Given this list of marker genes Vipr2, Plp1, Rab8b, Ndufaf4, Fat3, Pter, Ncr1, Nfat5, Hoxd8, Wscd2, Adam10, Acot8, Ppp3r2, Unc5d, Spty2d1, Cask, Ctdspl2, Mtarc1, Sall2, Erbb4, Itprid2, Gria1, Igfbp2, Pnpt1, Serinc5, Slc38a9, Atp11c, Dpyd, Gm7609, Papolg, Gata6, Nphs2, Mef2c, Bicd1, Zfp503, Vegfa, Dennd5a, Dtna, 4930562C15Rik, Magi1, Mbnl3, Pik3ca, Cklf, Tead1, Epha7, Ank, Wdr7, Zfp710, Unc80, Zfp472, Drp2, Cyp3a44, Ddx6, Ppip5k2, Cldn19, Tbc1d8b, Pak2, Pnpla8, Zfp345, Zfp967, Cnot1, Tspan2, Tnik, Rngtt, Foxn2, Nptx1, Nexmif, Rbfox2, Cadm2, Kcnj6, Zbtb10, Sh3d19, Ankrd44 (NCBI Gene Id 545320), Nrf1, Zfp966, Pappa2, Or4n5, Samd8, Chrdl1, Gcg, Zfp1005, Etv6, Fbxo11, Foxp3, Vps50 (VPS50 EARP/GARPII complex subunit), Ccdc70, Mapk8, Hhip, Ark2c, AW554918, Lin54, Map1b, Cdc27, Fam3c, Pcdh20, Nlrp4b, Raly, Gpm6a, Pde1c, Dynlt5, Gng2, Slc8a1, Ash1l, Slc24a2, Akap13, 1700028K03Rik, Dhrs9, Synj2bp, Npr3, Ptger2, Insyn2b, Gabrq, Septin11, 4930544G11Rik, Tnfsf10 (NCBI Gene Id 99628), Col25a1, Mafg, Ptpre, Igfbp5, Lpin2, Nova1, Pds5b, Btnl9, Shisa9, Man1a, Rhoa, Smarca1, Mip, Bsdc1, Akap6, Sh3rf1, Tmem252, Cdk6, Bnc2, Ddt, Mgat4c, Klkb1, Dio2, Gabpb2, Phactr2, Igf1, Ppp1r10, Cx3cr1 (C-X3-C motif chemokine receptor 1), Nrxn1, Zdhhc3, Grm4, Amhr2, Clic5, Sp1, Pla2g3, Crem (cAMP responsive element modulator), Zfp971, Iqsec3, Psg16, Trio, Cnot9, here is a description of the gene set: Mouse Gene Set: MIR_7014_3P from publication Chen Y, Wang X (PMID 31504780) Genes predicted to be targets of miRBase v22 microRNA mmu_miR_7014_3p in miRDB v6.0 with MirTarget v4 prediction scores > 80 (high confidence targets). species: Mus musculus